Given this list of marker genes RETREG2, ARHGAP45, NXT1, SRSF2, USP34, NRBP1, ANXA6, ZFP42, C12orf75-AS1, ENSG00000206649, LINC02052, SIRT5, GPR107, AKTIP, MIR4269, FTCD, MRPS36P3, EEF1A1P23, LOXL3, BAG1, CWC27, ATP6V1G1P6, RPS27AP11, MBD3, PREP, OTUD7B, CXADRP3, FGF14, TMEM63B, PIP4K2B, OR5AR1, CLEC1B, LINC01619, SNORA70, EZH1, CENPF, CCDC102B (coiled-coil domain containing 102B), LSM3, MYH9 (NCBI Gene Id 65212), VOPP1, LIN52, LINC02933, RPL29P28, TGFBR1, FAM217B, COX11, FXYD5, IGF2BP3, MPO, CDH26, MPPE1, SAXO5, IKZF1, PTK2B, TARS2, FABP5P5 (fatty acid binding protein 5 pseudogene 5, NCBI Gene Id 404767), UST-AS2, XYLT1, CLIP4, STAT6 (NCBI Gene Id 6778), LRRC63, RASGRP3, ENSG00000249236, CHODL, CNR1, EIF2S3, CD163L1, SYT1, HMGN2P31, NRIP1 (nuclear receptor interacting protein 1), NDUFV2 (NCBI Gene Id 4729), ALDH1A2, RASGEF1C, IL6ST, NUBPL, PRPF40A, HTR3D, RCAN1, ISL2, TPST2, PGRMC2, TAS2R40, LINC02954, LINC02077, CRYM, TRIQK, ATAD2B, MPP7, RNU1-19P, WRAP53, MIR4439, PLGRKT, VPS28, KIAA1217 (NCBI Gene Id 56243), NDUFS1, GPNMB, WARS1P1, ENSG00000287636, SQSTM1, SKP2, TNIP2, RNU6-1088P, RHOU, LINC01213, PDGFC, BTF3P16, SMC2-DT, TMEM230, HESX1, PDPK1, OTP (NCBI Gene Id 23440), CACNA1A, C12orf76, RAB30, COG3, MSC-AS1, TMEM183A, CD86, AP1M1, RNU6-316P, CACNA1C-IT1, CIITA, RNPC3, MINDY1 (NCBI Gene Id 55793), DDX24, USP53, C2orf92 (NCBI Gene Id 730797), CHRM3-AS2, CENPK, MEF2C, FIRRM, AFAP1L1, CHRM3, GON4L, TM2D1, ARRDC3-AS1, TTC28-AS1, RN7SKP216, PREB, BLTP1, SFPQ, MSH4, RAD51AP1, EDRF1, LINC02888, INTS6, KBTBD2, ARSG, AKAP7, FEZ1, USP40, CRK, SNORD59A, HIVEP3, PSMA4 (proteasome 20S subunit alpha 4), ATP2C1, VWA5A (von Willebrand factor A domain containing 5A), AP3M2, DIO2-AS1, ARHGEF7-IT1, CENPN, OR4A43P, MTCO3P29, PFN1, RBM28, DGKD, HLA-A, NEDD4, ABCG1, OLR1, ELMOD3, THNSL2, GNAS, AP1S2, TJP1, ESCO2, PPP3CA, SPHKAP, FBN1, NADK, BRWD1-AS1 (BRWD1 antisense RNA 1), PRKCH, DHX36, RHOBTB3, SMAD4, COL4A1, NUF2, NCEH1, MAP4K3-DT, TLN2, SLIRPP1, ARGFX, C1orf127, LINC02195, MIR99AHG, MYO1B, CRYZL1, ZFP41, DONSON, HTT, TMEM161B-DT, PDCD1LG2, SLC25A12, LINC02384, CTNNA1, GINS4, PALS2, CACNA1C, MINCR, LINC01485, TNFSF14, ZNF585B, ITIH5, CD70, ATP1A1-AS1, SAMSN1, ZNF771, SERPINB8, USP34-DT, MAP3K8, TM4SF4, DUS4L, MOB3B, LACTB, KCNC2, GPR183, NINJ2, GC, ENSG00000267882, DHRS4L2, ORMDL1, XPO1, FGD2, GSAP, AKAP5, LZIC, VPS35L, RPL7AP75, RNU6-954P, FNIP1, CRADD, CREBZF, RNA5SP113, ABCA6, DPT, LINC02325, ACAP1, MRPL1, MIR607, CTBS (NCBI Gene Id 7811), PLPPR4, TMBIM4, RGS13, MGME1 (mitochondrial genome maintenance exonuclease 1), FAM161B, SALL2, STXBP5-AS1, SLC25A28, RRM2, LINC02583, MTATP6P29 (MT-ATP6 pseudogene 29), RNU6-1014P, DDX50P2, TPM4, RN7SL68P, RANBP3L, TAS2R7, OTUD5, LINC00564, PCID2, SHROOM3-AS1, ERCC5, LINC01433, STPG3-AS1, BTC, RPL32P23, STXBP1, MYOF, SLC35A1, KTI12, CSF2, NUP37, RN7SKP13, RN7SL221P (NCBI Gene Id 106480982), LINC00431, PPP1CB-DT, LILRA1, RN7SL735P, SNX5, PRDX1, USP54, GART (NCBI Gene Id 2618), UTS2B, TMEM91, RNU6-571P, DDHD1-DT, TXNP6, NUP214, LUCAT1, KPNA4, MIR7848, SP140, TCEAL9P1, MAILR (macrophage interferon regulatory lncRNA), SLCO2B1, ENSG00000239096, RNU2-12P, RGS6, IFT46 (intraflagellar transport 46), GRB10, SLC25A28-DT (NCBI Gene Id 123466211), CDC14B (NCBI Gene Id 8555), SPOCK3, MIR3945, CALD1, ENSG00000202059, LINC00184, ADGRG7, ITPK1, FAM118A, EFTUD2, ATP8B4, ENSG00000235066, C3orf18, RNA5SP493, CLASP1, MAP2K3, SPESP1, MRPS6P4, KRT18P24, MEIS1-AS2, HMGB1P32, NEMP2, ANKRD13C, CDK2AP1, DNAJC18, STPG1, CCDC107, REG1CP, TLK2, GPR89A, PRKG2-AS1, PHACTR3, LGALS12, EXOC4, MAPKAPK3, GRIN2A, GEMIN8, SARNP, LINC01014, ZNF175 (NCBI Gene Id 7728), BPNT2P1, SRP72P2, NOP14-AS1, INSIG1, TMX4, SMC3P1, PIGL, TRG-AS1, WAC, ZEB1, DENND2D, MIR4256, TTN, HOXB-AS2, MAPK6P1, ANKIB1 (NCBI Gene Id 54467), TP63, MIR1321, LINC01865, LILRA2, P2RY1 (NCBI Gene Id 90963), CHMP4AP1, PRH1, RPS3AP18, SSPN, USP3, SAP30, MKX-AS1, PRXL2A, ACSS2, PPP2R5C, RBX1P2, CD48, SYNM-AS2, MAP3K6, DCAF8, PSMA3, ATG13, CBX3P5, SRFBP1, MMP8, PPCDC (phosphopantothenoylcysteine decarboxylase), IQCF5, ENSG00000201346, DEPTOR, POC1B (NCBI Gene Id 91413), INTU, LINC02073, TMEM100, PARK7, DPEP1, AKAP11, HARS2, SETD1A, LYRM9, RHOC, NCAPD2, CDC37, NNT-AS1, RNF186, DZIP3, TMBIM6 (NCBI Gene Id 7009), SAMSN1-AS1, CYTIP, NELFCD, DOCK10, RPL36AP38, HOXB3, MIR153-2, AHCYP2, MACO1, LINC01132, APPL1, ZNF846, RNA5SP44, RAB7A, AOC1, MECR, CFAP107, FLJ46284, THBS4, MAP1S, WWTR1, IFITM3P6, MFSD11, ATP23, LCN10 (lipocalin 10), CD160, GPBP1L1, DNAH8, SP100, IGHV3-64D, HDLBP, PHF1, MLYCD, SLC8A1-AS1, YES1, CLEC16A, MON2, STK38L, ZNF33CP, GDE1, RNU6ATAC32P, SNRPB, CLTC, TLK1, MIR196A1, HMGB1, CLU, DDHD1 (DDHD domain containing 1), TIAL1, SERPINE4P, MDM2, ZC3H4, ATP5PBP1, SCAPER (NCBI Gene Id 92909), GLUL, PCDHGB9P (NCBI Gene Id 84055), PIGQ, CD83, LINC00682, CSTF2T, CCR7, CLMP, SCARB1, RAD17P1, HIVEP1, CD59, HDAC2-AS2, PROCR, LINC02901, SMARCA2, ENSG00000232080, SRSF3, ARMC9, APLF, TP53BP1, PSEN1, MBP (myelin basic protein), CYP1B1-AS1, AP2B1, MCM9, SLC34A2, EPB41L2, UBE2Q1, FN1, ENSG00000259584, ATG4A, MSANTD3, NGEF, CFDP1, GREB1, PDGFRA, ESRRG, AZI2, TMPO, LINC02149, REL-DT, MTCO1P14, UBAC2, SANBR, ENSG00000283380, SLC39A8, STYK1, CLDN4, MRPL3, MEIS1, EMP1, ZFR2, CTSH, NACC1 (nucleus accumbens associated 1), ATG7, ACOXL, TBC1D1, HTATSF1P2, RPL6, HECTD1, BBC3, RN7SL646P, FAIM, SATB1, STATH, SNORD53, MIPEP, C2orf74, RN7SK, PIK3C3, RN7SL674P, PLCL2-AS1, GSTO2, PYGB, DENND2B-AS1, ABCA13, ALDOA, OR7A3P (NCBI Gene Id 8589), CAPZA2, PRKAG2, LINC01588, SLC1A3, ZNF385D, TNC, TCF7L2, FRS2, SQOR, ADAMTS7P4, MRPS31P1, PDGFRL, RPL29P29, DHX32, PSMD1, NPAS2, WFDC11 (NCBI Gene Id 259239), P4HB, LINC01262, ATXN2, SLC4A8, S100A5, SLC26A4, GCK, DPP3-DT, BLTP2, LRIG3, CAB39, NXF4, HMGB3P32, ANK3, YOD1, DPH5-DT, RBMS1, PURPL (NCBI Gene Id 643401), MUC19, RWDD1, RN7SL568P, F13B, TTN-AS1, HMGB3P26, EPHA4, STXBP4, TJP2, IQCC, SNRPCP19, ETS1-AS1, FAM149B1P1, PTHLH, NEMP2-DT, THUMPD3, CLDN12, RNA5SP325, FBXO27, HPS4, LSM14A, FOCAD, LINC00649, OTUB2, LINC02392, HOOK2, RNU2-2P, MAPK6, AZIN1, LIMK1, B3GNT4, MYO16-AS2, TMEM212, AFDN, ATP6V0E1P2, GSN, LIMA1, OR4C16, MYEOV, ALAS1, CXCL10, KDM2B, TWF1, SLC12A8, MIR155HG, HNRNPRP1, SLC13A4, GCNT1, RNU6-1011P, CEBPZOS, FBXO38, ACOXL-AS1, TENT4B, ABCA15P, SOX2, LINC02306, TTC38, CPEB4, PLA2G7, ENTR1, MARK2, RP9, TRIM59 (NCBI Gene Id 353185), LINC01846, COMMD6, PCNX1, HMGN2P8, ACTBP11, MSH2, PTPA, PTPN2, MBIP, LINC02324, RPS15AP3, CEP57, NUCB2, ZNF687-AS1, CDC42SE2, ATG5, SMG6, CHI3L2, CAPRIN2, LINC01392, CBX5, THOC1-DT, MTND2P7, RSPO2, GTF2E2, MYO16, EMP3, STT3A, BEST3 (NCBI Gene Id 84821), ING3 (inhibitor of growth family member 3), SLC1A2, CIBAR1, DMAC2L, IL1R2, NFXL1, ZDHHC13, RAD51B, DCAF8-DT, BCL2L1, PDE4A, AIM2, NIBAN2, HLA-DQA1, MRPS36P5, CPAMD8, PABPC1, ERICH3, RHOH, PDK2, TM7SF3, SMC2 (NCBI Gene Id 10592), LINGO2, CDC42BPB, KCTD3, PAPPA-AS2, HDAC9, RNU4-1, GPR15, LINC01304, UBA6-DT, OR4P4, METTL21A, ADSS1, MRPL46, OR7E85BP, H4C5 (NCBI Gene Id 8367), CNTD1, SLC4A10, CD69, LAMTOR5-AS1, CDK5RAP2, LZTFL1, VNN3P, FBRS, MRPL42P3, H2BC7, MAP3K4, SUB1, MYO1D, SSUH2, PPP1R3B-DT (PPP1R3B divergent transcript), JMY (junction mediating and regulatory protein, p53 cofactor), BRF1, OR4C50P, LINC01841 (NCBI Gene Id 105372288), NEK6, FYTTD1, ZNF224 (NCBI Gene Id 7767), NDUFB5, STAT4-AS1, GALNT13, POLDIP2, ARSB, TTC21B, EEF1GP4, PHKB, LINC02480, TFIP11, LRRFIP2, EPHX4, CNPPD1, LINC02526, CIP2A, PHF11, LTBP1, IGLV3-22 (NCBI Gene Id 28795), ETNPPL, TG, NDUFA9, SCYL3, ANTXR2, ATP6V1B1, ARHGAP24, ARL2BPP4, ARID1B, GPR171, ITGAL, DST, VWC2L, OR51M1, MTND1P29, ARHGEF12, LINC03108, ACMSD, SGK1, VIT, DPPA3P7, LINC00222, ZYG11AP1, ATP13A4-AS1, EIF4E, LINC01179, SEPTIN7P2, DAAM1, SASH1, RNA5SP374, NEIL3, NAP1L4, PKM, DHX33, HOMER1, CLDND1, DHRS4-AS1, COG2, RPL7AP66, HNRNPA1, BAGE2, LINC01102, CISH, CHCHD3P1, ARPP19, LSMEM1, PCMT1, ZDHHC20, ENSG00000253452, RIN1, NR2C2, LINC02144, DAB2IP, LNCATV, FHIT, NIPAL2, MCCC2, TICAM1, PLAAT2, BIN1, FBXO48, HOXC13-AS, RN7SKP139, CMSS1, EXOSC10, MIRLET7I, LINC02579, OR2G6, ANKRD13C-DT, TOMM40P4, DNAH7, ALAS2, RNU6-821P, GSX1, CENPI, AQP3, CREB1, FILIP1, LATS1, USP45, TRMT1, SRD5A3-AS1, MCFD2, MIR298, SOCS5P5, CEDORA, FCF1P8, LINC01271, GSTA4, RETSAT, RNU6-374P, ITGA6-AS1, CYTH1, TBL1X, LONRF1, UBE2V1 (ubiquitin conjugating enzyme E2 V1), THOC1, IFT27, ENTPD6, EGR2, SEC31B, PAN3, HEY2-AS1, IRAK1BP1, LINC01152, LINC02099, DPPA3P9, SLC38A2, PPA2, PSMC3IP, CCL5, GBA1, BCAP29, SUSD4, HSD17B7, DPP8, CFLAR, EGFEM1P, FUBP3, ATPAF1, KCTD11, C3orf85 (chromosome 3 open reading frame 85), SBNO1, ENSG00000183154, LINC01934, FGF12-AS3, CAPN8 (NCBI Gene Id 644151), RDM1P3, STRN4, ZCCHC14, LARP4, OSBPL6, KCNE3, GALNT5, STRN3, LINC00944, CRYGGP, PPP1R11, GFPT2, ENSG00000267764, OR51A2, TMEM229B, AP5B1, ATP13A4, PDE6C, LINC00511, HRH1, PTGER4, DDX50, UBE2S, LINC01366, LRRCC1, BAG6, RPL3P3, TEX48, NXPE1, CNTN1, CTBP2P7, PLA2G6, WDR74, CADM1 (cell adhesion molecule 1), ATIC, ZFPM2-AS1 (ZFPM2 antisense RNA 1), PRECSIT, PSPC1, KIF16B, IL17F, NRXN3, KCTD4, RPL10P14, MIR1296, MFSD1, TP53, CDHR2, COL6A5, ATG16L1, AKAP9, PNP, PHF12, ENSG00000274385, ENSG00000225647, CDH8, AGBL2, UNKL, ARL14EPL, PDE6A, KLC4, RPRD2, RN7SL48P, ETV1, PCDHA13, BTRC, BCL3, CSF2RA (NCBI Gene Id 8282), CA5BP1, CASP6, CPT2, NELFB, ACTA2, ENSG00000265222, SUMO2P7, PMAIP1, ZNF687, OR7E90P, PIEZO2, KNG1, MAP3K7CL, GYG1, CCR5, CACNA2D4, TMX3, NPFF, LNX1-AS1, ZSCAN16-AS1, GREB1L, NMI, PMCH, PPP6R1, KCNMB2, IPO4, HSP90AB2P, RPA3, OR51K1P, SH2D1A, DKK4, RNU6-1149P, NT5DC3, KCNQ5, ALDH6A1, BFSP1, NFATC2, KNL1, MEIS2 (Meis homeobox 2), RNU6-951P, RP1, SPG11, NBAS, H4C16, RPS16P2, WBP11P1, TM9SF4, HNRNPH1P3, SLC15A4, RNU6-165P, SMIM7P1, CYP2R1, GOSR2, TPRG1, CXCR1, FUNDC2P3, PFDN1, PTRHD1, SIPA1L1, RNA5SP192, RNPEP, ENSG00000201316, ATF7-NPFF, AHI1, TCF7, RNU6-971P, CFTR, ENSG00000189316, REL, BUD13, P4HA1, PHTF1, THADA, GULP1, RPS12, GAR1-DT, EML2, TPTE2-AS1, MIR6083, RMRP, RNU6-1081P, PHF6, PRMT5P1, FHOD3, KSR1, CD96, RPS27P1, MIR3926-2, RPL6P19, SSBL6P, DOCK7, GRAMD1A, RRAGAP1, IKZF2, PBX1, OPRM1, EIF2A, CHD8, ARNT2, NMNAT1, AMZ2P1, H6PD, LNCTSI, TMX1, CCL3, MTIF2, LINC02427, ODF2L, SLC16A5, ELOCP28, RNU6-488P, SEPTIN2, LINC02755, SLC12A6, RNU7-27P, NAMPTP2, DGUOK, HECW2, KMT2A, STX1A, GSTP1, IL2RA, B4GALT7, SP110, LINC02274, MIGA1, TCP11, CCM2, RN7SL172P, FOLH1B, HIF1A, LINC01111, CCDC25, SLC25A32, CLEC2D, MAPRE2, DPP3, SLC9A9, LINC01180, PCBP1-AS1 (NCBI Gene Id 652470), CAMTA2, LINC02546, LINC02694, SDHAP4, METTL18, FLI1, CENPO, H2BC8, SLC41A2, SYNJ1, MIR4801, MPRIP, ANAPC16, TMEM243, DTNB, TBL1XR1, ENO3, TRPC4, STAT1, ANP32E, COMMD2, SYCP2, ACTRT1, DDR2, NRP1, JCAD, CNTN3, RPS3AP27, BAZ2B, WDR1, SOX5, DNAH14, HCFC1-AS1, LINC02458, DIAPH3, CSK, PRPF40B, SLC30A6, SNORD13D, MCPH1, RNU6ATAC4P, ATXN7L1, ITFG2, ATP6V0D2, ARL6IP5, INTS4, POLG2 (DNA polymerase gamma 2, accessory subunit), ITGB4, ASS1P12, OR3B1P, ECE2, FRG1HP, CDKAL1, TECR, CSF1R, CTNNBL1, TRPC1, DNAJB4, SLC30A6-DT, PHF14, ANO3, MICU2, RCOR3, TMEM52B, ABCB9, OR2M7, PTPN22, SEZ6L, PLEKHA5, PRDM1, ENSG00000262147, DEFB128, FAS, OTOGL, TBC1D5, LINC01675, SLC22A23, NUP43, ENSG00000221040, ALG3, LINC01585, MTHFD1, CEP72, KCNMB3, MIR4423, PDHA1P1, H3C11, SULT6B1, MIR1471, SLC35G1, ASPH, FAM107B, ZFAS1, LINC02345, NSRP1, RNF43, SLC4A4, HTR5A, PON1, CPD, COL4A5, EVA1A-AS, MIR3668, MTMR14, LINC02890, LMNA, LINC02997, DTX4, LINC02541, MAGOH2P, ENSG00000265246, C3orf49, NFATC3, RNF135, RNA5SP137, PALLD, PYGL, ANKRD28, IL23R, RNF138P2, LINC03110, PRKD3, NME7, SYNE2, LINC00314, RAPGEF6, LINC00544, DLG2-AS2, LINC02842, FMO5, CCNT1, CFAP221, GLB1, MAP4K2, ARHGAP31-AS1, CLIC5, IFT88, TRGV6, FKBP1A, BRWD1, LINC01605, TEX26-AS1, LINC01270, ARFGEF2, PTMAP5, UBE2H, AMPD3, LINC00533, ENSG00000235978, MACF1, TNIP1, CHSY1, IER5L-AS1, NR2C1, STMN1, SLC25A46, SRSF7, ZSWIM5, RPL23AP55, NUMB (NCBI Gene Id 94910), CBLB, COLGALT2, TMEM199, CATSPERB, PPP2R2B-IT1, HCG14, RFFL, FABP9, RHEB (Ras homolog, mTORC1 binding), ENSG00000214803, PLXND1, ENSG00000236935, PDP1, CUL9, MED12L, DLD, here is a description of the gene set: Genes containing one or more binding sites for (HBZ) in their promoter regions (TSS -1000,+100 bp) as identified by GTRD version 20.06 ChIP-seq harmonization. Human Gene Set: HBZ_TARGET_GENES from publication Yevshin I, Sharipov R, Kolmykov S, Kondrakhin Y, Kolpakov F (PMID 30445619) species: Homo sapiens